The following is a description of a gene set: Any process that activates or increases the frequency, rate or extent of potassium ion transmembrane transport. Human Gene Set: GOBP_POSITIVE_REGULATION_OF_POTASSIUM_ION_TRANSMEMBRANE_TRANSPORT studied in species Homo sapiens, and this is the list of marker genes: KCNC1, LRRC26, KCNJ2, KCNE5, KCNQ1, LRRC52, GALR2, FLNA, ATP1B3, GAL, NPPA, FHL1, OPRK1, LRRC55, KCNC2, KCNN4, AKAP6, NOS1AP, MIR21, ATP1B2, KCNH2, KCNIP2, AKAP7, KCNE1, AMIGO1, ANK2, ATP1B1, ANO6, STK39, LRRC38, EDN3